The following is a description of a gene set: The chemical reactions and pathways involving any disaccharide, sugars composed of two monosaccharide units. species: Homo sapiens Human Gene Set: GOBP_DISACCHARIDE_METABOLIC_PROCESS, and this is the list of marker genes: MGAM, GAA, IDUA, B4GALT1, TREH, LALBA, LCT, SI